The following is a description of a gene set: Human Gene Set: GOBP_ADENOSINE_TRANSPORT species: Homo sapiens The directed movement of adenosine, adenine riboside, into, out of or within a cell, or between cells, by means of some agent such as a transporter or pore., and this is the list of marker genes: SLC29A2, SLC28A2, SLC29A1, SLC29A4, SLC29A3